The following is a description of a gene set: studied in species Homo sapiens Human Gene Set: HP_NEOPLASM_OF_THE_TONGUE Neoplasm of the tongue A tumor (abnormal growth of tissue) of the tongue., and this is the list of marker genes: C2CD3, SMARCB1, PIK3CA, TMEM231, TCTN3, CASP10, SMARCE1 (SWI/SNF related, matrix associated, actin dependent regulator of chromatin, subfamily e, member 1), DYNC2H1, SMO, OFD1, WDPCP, PDGFB, GJB2, TRAF7, SUFU, MAN2C1, AKT1, GJB6, TMEM216, KIAA0753, PDE6D, FAM149B1, FAS, EDN1, FASLG, KIAA0586, WRAP53, CPLANE1, TOPORS (NCBI Gene Id 641432), BAP1, INTU, PLCB4, KAT6B, DDX59, TMEM107, TERT, CEP120, NF2, MDM4, GNAI3, NEK1, KIF7